Given this list of marker genes Fbll1, Fbxo11, Suz12, Setd7, Prdm9, Kmt2d, Eef1akmt1, Prmt9, Pcmt1, Setbp1, Kmt2c, Ntmt2, Mettl13, Nsd1, Setd5, Prmt2, Mecom, Prdm8, Kmt2b, Jarid2, Ezh2, Nsd2, Prmt6, Smyd2, Suv39h2, Eef1akmt2, Setd3, Mettl21a, Ndufaf7, Setdb1, Dph5 (NCBI Gene Id 99837), Ehmt1, Ash2l, Prmt5, Ash1l, Mgmt, Fam98b, Suv39h1, Vcpkmt, Setdb2, Eef2kmt, Setd4, Carm1, Camkmt, Sirt7, Mettl9, Kmt5a, Dnmt3a, Armt1, Smyd3, Trmt112, Smyd5, Prdm16, Icmt, Kmt5c, Prdm6, Mettl21c, Ezh1, Mettl18, Mettl21e, Wdr5, Mettl22, N6amt1, Fbl, Etfbkmt, Setd1b, Setd2, Prmt1, Kmt5b, Smyd1, Lcmt2 (NCBI Gene Id 329504), Kmt2a, Prdm13, Pcmtd2, Setmar, Ntmt1, Setd6, Setd1a, Mettl23, Nsd3, Fam98a, Atpsckmt, Kmt2e, Dot1l, Prmt8, Antkmt, Eef1akmt4, Prmt3 (protein arginine N-methyltransferase 3), Hemk1, Pcmtd1, Ehmt2, Prmt7, Lcmt1 (leucine carboxyl methyltransferase 1), Eef1akmt3, here is a description of the gene set: Mouse Gene Set: GOMF_PROTEIN_METHYLTRANSFERASE_ACTIVITY species: Mus musculus Catalysis of the transfer of a methyl group (CH3-) to a protein.